The following is a description of a gene set: Any process that modulates the frequency, rate or extent of glycolysis. studied in species Homo sapiens Human Gene Set: GOBP_REGULATION_OF_GLYCOLYTIC_PROCESS, and this is the list of marker genes: PRKAG1, IFNG, P2RX7, SLC4A4, IGF1, GIT1, PFKFB1, SRC, FLCN, PSEN1, PRXL2C, PRKACA, PPARA, GAPDHS, OGT, IER3, ARNT, DDIT4, SIRT6, SLC4A1, EIF6, STAT3, MTOR, PRKAA2, ZBTB20, HIF1A, ACTN3, TIGAR, HTR2A, SLC2A6, NUPR1, NCOR1, FBP1, RPTOR, JMJD8, INS (insulin), GCK, CBFA2T3 (NCBI Gene Id 863), PRKAG3, MLST8, PRKAA1, EP300, ZBTB7A, UCHL1, HDAC4, TREX1, GPD1, INSR, MLXIPL, APP, MTCH2, PPP2CA, ARL2, PRKAG2, TRIM63, KAT2B